Given this list of marker genes CDC20, LMNB1, HJURP, CDKN3, BUB1, PLK4, MAD2L1, MKI67, BUB1B, TPX2, ABCC1, PRC1, PBK (NCBI Gene Id 55886), CENPA, CDK1, NQO1 (NCBI Gene Id 4834), GINS1, ATAD2, POLQ, DTYMK, CDCA8, NSD2, ZWINT, PCLAF, NUSAP1, BARD1, POLA2, HMGB2, NCAPG2, TYMS, BIRC5, ASPM, PLK1, FANCI, RRM2, FOXM1, ASF1B, NCAPG, DSCC1, KIF4A, MCM4, AURKA, HMMR, RFC4, CDC6 (NCBI Gene Id 990), NPIPA1, RAD51AP1, TOP2A, OIP5 (Opa interacting protein 5), FOSB, CENPM, NEMP1 (NCBI Gene Id 23306), TK1, RRM1, here is a description of the gene set: Human Gene Set: KANG_DOXORUBICIN_RESISTANCE_UP species: Homo sapiens from publication Kang HC, Kim IJ, Park JH, Shin Y, Ku JL, Jung MS, Yoo BC, Kim HK, Park JG (PMID 14734480) Genes up-regulated in gastric cancer cell lines: doxorubicin resistant vs sensitive. PURPOSE: A major obstacle in chemotherapy is treatment failure due to anticancer drug resistance. The emergence of acquired resistance results from host factors and genetic or epigenetic changes in the cancer cells. The purpose of this study was to identify differentially expressed genes associated with acquisition of resistance in human gastric cancer cells. EXPERIMENTAL DESIGN: We performed global gene expression analysis in the acquired drug-resistant gastric cancer cell lines to the commonly used drugs 5-fluorouracil, doxorubicin, and cisplatin using Affymetrix HG-U133A microarray. The gene expression patterns of 10 chemoresistant gastric cancer cell lines were compared with those of four parent cell lines using fold-change and Wilcoxon's test for data analysis. RESULTS: We identified over genes differentially expressed in 5-fluorouracil-, cisplatin-, or doxorubicin-resistant gastric cancer cell lines. Our expression analysis also identified eight multidrug resistance candidate genes that were associated with resistance to two or more of the tested chemotherapeutic agents. Among these, midkine (MDK), a heparin-binding growth factor, was overexpressed in all drug-resistant cell lines, strongly suggesting that MDK might contribute to multidrug resistance in gastric cancer cells. CONCLUSIONS: Our investigation provides comprehensive gene information associated with acquired resistance to anticancer drugs in gastric cancer cells and a basis for additional functional studies.